The following is a description of a gene set: species: Homo sapiens Human Gene Set: ACTGCAG_MIR173P Genes having at least one occurence of the motif ACTGCAG in their 3' untranslated region. The motif represents putative target (that is, seed match) of human mature miRNA hsa-miR-17-3p (v7.1 miRBase)., and this is the list of marker genes: NKAIN1 (NCBI Gene Id 79570), FNBP1L, KANSL1, KAT7, UHMK1 (NCBI Gene Id 127933), MRGBP, DDX6, RAB6A, ANKRD50, RASGRP4, INPP5A, OLFM1, ACTR1A, CNOT6, PARD3B, RASAL2, SHTN1, LPAL2, TSHZ3, SNX27, NEUROG1, PPP6R3, KBTBD2, MARCKS, BCORL1 (BCL6 corepressor like 1), PPP2CA, RNF111, ZIC3, PARP6, COL12A1, FAM168B, RTL5 (retrotransposon Gag like 5), NTRK2, CDK17, MAP4, FKBP5, GABBR2 (NCBI Gene Id 9568), DHX57, DCAF7, ZNF462, PPP4R3A, NRDC (nardilysin convertase), BTF3, VEZT, EIF4G1 (eukaryotic translation initiation factor 4 gamma 1), ZFHX4, FSTL5, ZFR, SLITRK1, ARMC8, ARID2, MEIS1, CYTH1, PYM1, HIF1A, IGF2BP1, ZNF423, DDX5, MYO19, HDAC8 (NCBI Gene Id 7492), MACROD2, RAB11A, TM9SF4, PPP1R10, CSDE1 (cold shock domain containing E1, NCBI Gene Id 7812), FOXP1, CTR9, YTHDF2, FZD4, DENND6A, MAML3, RAB8B, MYO1D, VEZF1, TMEM62, TCERG1L, GTDC1, RAB21, TRAPPC10, SPRED2, RAP2C, CACNA2D4, CDK2AP2, CEP43, NR3C1, ACACA, OGT, YWHAG, CNOT4, NF2, HMGA2, VGLL4, ITSN1, MAX, VPS36, LIN28A, MIER3, KPNA3, RHOT1, EBF1, BRWD3, KCNMA1, SORCS2, USP33, CAMK2D, SOX11, HERC2P9 (HERC2 pseudogene 9), GTF2H1, KHDRBS1, ZFHX2 (NCBI Gene Id 85446)